Given this list of marker genes ATP5MC1, CCND3, IKBKE, STAT5A, TMEM256, ECI2, ATAD5, SNHG32, NDUFC2, TIMM17B, CTSH, KIFBP, SH3BGRL, VPS8, PRDX5, ANAPC1, IL27RA, ARHGEF6, TUBA1B, FRMD8, CHMP2A, RPS27L, SMARCAL1, PDCD4, MDH2, TMEM106C, COX15, CENPH, TRIM34, EXOC7, HOMER1, HSPA8, NUDT1, LYRM2, AURKAIP1, MMUT, HSDL2, FAF1, HDAC6, CSTPP1, ADCY7, CEP57L1 (centrosomal protein 57 like 1), CHEK1, ALDH6A1, PDSS2, GPI, NMT1, GTF3C6, MXD4, ACYP1, CLCC1, CCNG1, SLIRP, MARS1 (methionyl-tRNA synthetase 1), NDUFV1, ANTKMT, TMEM14C, LYPLA2, CD81, HAUS5, FMC1, NCBP2AS2, PSMD6, DNAJC19, CACNA1C, CCDC93, CSRP2 (cysteine and glycine rich protein 2), C12orf57, PHYH, DPY30, NEK1, ILVBL, PTRH2, POLE, NOP10, MTCP1, MRPL58, CNRIP1, PHF14, BPHL, ETFDH (NCBI Gene Id 2110), ORC1, NDUFB2, SSRP1, SELENOH, SLC28A2 (solute carrier family 28 member 2), MRE11, MMS22L, EXOC4, H2AJ, PRXL2B, PYCR2, ANAPC4, ABCD3, ZNF124, TUBB6, HMG20A, PARK7, DXO (NCBI Gene Id 1797), NAA38, DGCR6, FUNDC1, SLC2A6, NDUFAF3, SLC6A12, METTL26, PMM1, SEMA6D, ENDOU, SERHL2, CETN2, NDUFA7, ERP44 (endoplasmic reticulum protein 44), FAM193B, WASHC3, ACOT13, ZNF771, NMRAL1, DYNLL1 (dynein light chain LC8-type 1), MRPS14, STIL, DNAJB1, ALAD, POLR2I, PSME2, POLR2J, USP45, FAS, FAM111A, TMEM160 (NCBI Gene Id 54958), BRIP1, CDK2AP1, EEF1AKMT2, PRPF6, PPIB, DERA, APPL2, TCF4, TMEM14A, ABHD12, LAMTOR3, RGL1, CDC7, DNAJC9, EIF2AK2, NQO1, NUDT2, PAGR1, CNDP2, MAD2L1BP, RNF181, AHCY, SMIM19, SURF1, PTDSS2, CDK2AP2, CENPO, FBXL20, PTOV1, POGLUT2, MRPL34, CBR4, ANKRD54, DLGAP5, ITFG1, WDR6, S100A1, LSP1, CNST, NIPSNAP1, DNPH1, ENTPD7, PCCB, VKORC1, NSMCE1 (NCBI Gene Id 197370), PXN, TK1, YIPF1, VPS29 (VPS29 retromer complex component), EVL, NDUFS5, LAMTOR4, AHRR, AIMP1, ALG6, ADAM19, GPX1, ZNF623, ERMP1, SIRT5, MCCC1, CPT2, GDPGP1, ACP6, DYNLRB1, DCXR, CENPU, PSMC2, ATP5MF, RPS26, here is a description of the gene set: CD4+ T cells that selectively produce interleukin (IL)-17, are critical for host defense and autoimmunity1-4. Crucial for T helper17 (Th17) cells in vivo5,6, IL-23 has been thought to be incapable of driving initial differentiation. Rather, IL-6 and transforming growth factor (TGF)-β1 have been argued to be the factors responsible for initiating specification7-10. Herein, we show that Th17 differentiation occurs in the absence of TGF-β signaling. Neither IL-6 nor IL-23 alone efficiently generated Th17 cells; however, these cytokines in combination with IL-1β effectively induced IL-17 production in naïve precursors, independently of TGF-β. Epigenetic modification of the Il17a/Il17f and Rorc promoters proceeded without TGF-β1, allowing the generation of cells that co-expressed Rorγt and T-bet. T-bet+Rorγt+ Th17 cells are generated in vivo during experimental allergic encephalomyelitis (EAE), and adoptively transferred Th17 cells generated with IL-23 in the absence of TGF-β1 were more pathogenic in this experimental disease. These data suggest a new model for Th17 differentiation. Consistent with genetic data linking the IL23R with autoimmunity, our findings re-emphasize the role of IL-23 and therefore have important implications for the development of new therapies. Human Gene Set: GSE23505_IL6_IL1_VS_IL6_IL1_TGFB_TREATED_CD4_TCELL_DN species: Homo sapiens Genes down-regulated in CD4 T cells treated with IL1B and IL6 versus those also treated with TGFB1. from publication Ghoreschi K, Laurence A, Yang XP, Tato CM, McGeachy MJ, Konkel JE, Ramos HL, Wei L, Davidson TS, Bouladoux N, Grainger JR, Chen Q, Kanno Y, Watford WT, Sun HW, Eberl G, Shevach EM, Belkaid Y, Cua DJ, Chen W, O'Shea JJ (PMID 20962846)